The following is a description of a gene set: Mouse Gene Set: GOBP_POSITIVE_REGULATION_OF_FAT_CELL_PROLIFERATION species: Mus musculus Any process that activates or increases the rate or extent of fat cell proliferation., and this is the list of marker genes: Fgf16, Vstm2a, Fgf10, Pid1, Ppard